Given this list of marker genes FOXO3 (forkhead box O3), RUNX3, SMAD4, SMAD3, BCL2L11, here is a description of the gene set: RUNX3 regulates BCL2L11 (BIM) transcription studied in species Homo sapiens Human Gene Set: REACTOME_RUNX3_REGULATES_BCL2L11_BIM_TRANSCRIPTION